Given this list of marker genes IFIH1, ALX1, SF3B2, POLR1D, RPL26, ADNP, POLR1A, FREM2, DHODH, ESCO2, FGFR1, FLI1, TXNL4A, CDH11, SEMA3E, FRAS1, SF3B4, POLR1C, PSAT1, SAMHD1, EIF5A, ADAR, TWIST1, RNASEH2C (ribonuclease H2 subunit C), EDNRA, TCOF1 (NCBI Gene Id 6949), TWIST2, ZPR1, CHD7, SLC25A24, RNASEH2B, CCNQ, KCTD1, FREM1, RNU7-1, RNASEH2A, GRIP1, PHGDH, RIPK4, KRAS, TREX1, MAB21L2, POLR1B, LSM11, here is a description of the gene set: Aplasia/Hypoplasia of the eyelid Absence or underdevelopment of the eyelid. species: Homo sapiens Human Gene Set: HP_APLASIA_HYPOPLASIA_OF_THE_EYELID